The following is a description of a gene set: Human Gene Set: GSE43957_UNTREATED_VS_NACL_TREATED_ANTI_CD3_CD28_STIM_CD4_TCELL_DN from publication Wu C, Yosef N, Thalhamer T, Zhu C, Xiao S, Kishi Y, Regev A, Kuchroo VK (PMID 23467085) Genes down-regulated in CD4 T helper cells Th0: control versus NaCl treatment. Th17 cells are highly proinflammatory cells that are critical for clearing extracellular pathogens like fungal infections and for induction of multiple autoimmune diseases1. IL-23 plays a critical role in stabilizing and endowing Th17 cells with pathogenic effector functions2. Previous studies have shown that IL-23 signaling reinforces the Th17 phenotype by increasing expression of IL-23 receptor (IL-23R)3. However, the precise molecular mechanism by which IL-23 sustains the Th17 response and induces pathogenic effector functions has not been elucidated. Here, we used unbiased transcriptional profiling of developing Th17 cells to construct a model of their signaling network and identify major nodes that regulate Th17 development. We identified serum glucocorticoid kinase-1 (SGK1), as an essential node downstream of IL-23 signaling, critical for regulating IL-23R expression and for stabilizing the Th17 cell phenotype by deactivation of Foxo1, a direct repressor of IL-23R expression. A serine-threonine kinase homologous to AKT4, SGK1 has been associated with cell cycle and apoptosis, and has been shown to govern Na+ transport and homeostasis5, 6 7, 8. We here show that a modest increase in salt (NaCl) concentration induces SGK1 expression, promotes IL-23R expression and enhances Th17 cell differentiation in vitro and in vivo, ultimately accelerating the development of autoimmunity. The loss of SGK1 resulted in abrogation of Na+-mediated Th17 differentiation in an IL-23-dependent manner. These data indicate that SGK1 is a critical regulator for the induction of pathogenic Th17 cells and provides a molecular insight by which an environmental factor such as a high salt diet could trigger Th17 development and promote tissue inflammation. studied in species Homo sapiens, and this is the list of marker genes: IL17RA, EGR2, MAPK6, MRPS34, TYSND1, COQ3, BPGM, CASP6, DENND5A, SBF2, MIEN1, GK, BGN, EGF, ABHD14A (NCBI Gene Id 25864), CAMSAP1, MAP3K8, SLC1A4, FGA, PLGRKT, MRAS, NBL1, RAN, PDPN, CDKN2D, IL4R, SH2B3, ORC2, C5orf15, MIDN, MRPS18B, NEUROG2, ARHGAP1, KPNB1 (NCBI Gene Id 3837), SSU72, ZNF703, LATS2, SOS1, TMEM222, CYTH1, PON3, UGCG, MRPS25, ENTPD7 (NCBI Gene Id 57089), BNIP3L, REEP6, KPNA3, CELF2, TXNRD1, PCBD2, FABP7, PTGER4, FYTTD1, TSG101, ARPC1A, STX7, CEP350, ARFRP1, SEMA6B, PRDX4, TADA1, DUSP2, ZNF207, RCAN1, TBC1D15, DNAAF10, VPS13C, AGFG1, PTPN11, DDIT4, MARCKS, UBXN4, FXYD5, PLA2G5, IL10, CDK2AP2, TWIST2, GADD45B, BCL2L11, NOC4L, ZNF598, AHR, MCOLN2, BHLHE40, C3, ADARB1, SUGT1, ZFAND5, SEC63, BACH1, RNF19B, CSNK1A1, SDHD, NICN1, EEF1B2, MRPS26, ERP44, AMBP (NCBI Gene Id 259), FMR1, CDK5, IL18R1, SAA1, MYD88, FEM1B, SELPLG, KIAA2013, VPS37C, DUSP16, TOR1AIP2, ICAM1, STRN, GADD45A, SELE, LGMN, MRPL35, VCP, NNMT (nicotinamide N-methyltransferase), NOCT, TUBB6, GRSF1, CTPS2, GLA, TBC1D22A (NCBI Gene Id 25771), U2AF1, CKAP4, ALOX12B, OTULINL, METAP1, CD40, CCL13, BPIFA2, SMS, CH25H, ADORA2B, OGA (O-GlcNAcase), SNAP23, EIF1AY, HLX, DCTN3, CLIC4, GLRX3, PAFAH1B2, CCL7, KDR, DDX18, PSMB5, GRN, FYN, TNFRSF1A, TXNDC16, NDUFS3, MT2A, UBE2D2, ALDH3A2, ZFAND2A (NCBI Gene Id 90637), ADCY4, SELP, STX5, COPS5, TIMP3 (TIMP metallopeptidase inhibitor 3), FBXL5, RNH1, PREPL, SNX12, RAB18, NDUFA9, CXCL9, NFIL3, EIF1AX, DR1, IRF8, MTHFD2, HK2, RAB24, NDUFB10, MMP15, STRN3 (NCBI Gene Id 29971), C1D, CISD1, SPPL3, MT1E, GTF2A1, FOXM1 (NCBI Gene Id 2305), PROCR, GMPPB, NAPSA, SPHK1, MYH2, TAC1, RAC3, IRF1, ERRFI1, NDUFA2, FCGR1A, LTF, RRN3, TSPAN4, WIPI2, CCN1, ETFB